Given this list of marker genes PARP2, RNU6-2, RMRP, RNU6-1, RNY3, RN7SK, RNY4, RNY1, RNU6ATAC, GSTA4, GHET1, RNU6-9, MED16, CCDC107, ERCC1, RNU6-8, RPPH1, ZFP36L1, RNU6-7, TMEM259, here is a description of the gene set: from publication Yevshin I, Sharipov R, Kolmykov S, Kondrakhin Y, Kolpakov F (PMID 30445619) Genes containing one or more binding sites for (BRF2) in their promoter regions (TSS -1000,+100 bp) as identified by GTRD version 20.06 ChIP-seq harmonization. Human Gene Set: BRF2_TARGET_GENES studied in species Homo sapiens